Given this list of marker genes SPTLC2, KRT9, MORC2, MPV17, VWA1, GALC, CLTCL1, SETX, ADA2, ATP13A2, MTRFR, ATXN1, BSCL2, ATL3, KRT1, HK1, HARS1, ATL1, POLG, PNPT1, GDAP1, RAB7A, SPTLC1, SCN9A, KRT16, KLHL9 (NCBI Gene Id 55958), NARS1, SACS, VCP, DHH (desert hedgehog signaling molecule), DCAF8 (DDB1 and CUL4 associated factor 8), NDRG1, DDHD1, RNF170, PLEKHG4, TWNK, PMP22, here is a description of the gene set: Human Gene Set: HP_IMPAIRED_TACTILE_SENSATION studied in species Homo sapiens A reduced sense of touch (tactile sensation). This is usually tested with a wisp of cotton or a fine camel's hair brush, by asking patients to say 'now' each time they feel the stimulus. Impaired tactile sensation